The following is a description of a gene set: species: Mus musculus Genes predicted to be targets of miRBase v22 microRNA mmu_miR_6985_3p in miRDB v6.0 with MirTarget v4 prediction scores > 80 (high confidence targets). Mouse Gene Set: MIR_6985_3P from publication Chen Y, Wang X (PMID 31504780), and this is the list of marker genes: Dcaf12, Vgf, Tead1, Rreb1 (NCBI Gene Id 68750), Bcor, Insyn2a, Rpn2, Dio1, Arih2, Cd99l2, Nhlh2, Wnk2, Vdac3, Cyp2c50, Sv2b (synaptic vesicle glycoprotein 2b), C2cd2, Apaf1, Hsdl1, Strbp, Ror1, Tmem170b, Sox8, F8, Trim6, Spesp1, Grm5, Myh9, Tsc22d2, Ptbp2, Fndc3a, Bltp1, Gata2, Slc5a1, Tmem178b, Cnr1, Spata13, Rpgrip1l, Gns, Chst2, Amotl2, Atad2b, Mme, Slitrk6, Gcc2, Nup58, Insm2, Tmem161a, Zhx1, Mknk2, Patz1, Slc35f1, Gpd2, Homer1, Dyrk1a, Eya1, Zbtb33, Usp46, Gata3, Pdzk1ip1, Bcl10, Dzip1l, Dtx4, Plppr4, Map1b, Ufsp2 (NCBI Gene Id 66429), Zfp36, Nipal4, Cpeb3, Cdh11, Gramd1c, Fbxo46, Acer2, Slc39a6, Dnajc5b, Apc, Sox11, Stx8 (syntaxin 8), Gse1, Braf, Il6ra, Mrps14, Cds2, St6galnac3, Btg1, Appbp2, Chn2, Midn, Ino80d, Atp5mc3, Serf2, Edil3, Fbxw7, Lctl, Slc7a11, Mmd, Chd7, Kpnb1, C2cd5, Raph1 (NCBI Gene Id 77300), Tia1, Hoga1, Abhd17c, Adamts6, Nlk, Cdk5r1, Pdha1, Ppm1k, Sall2, Edrf1, Rps6kb1, Dmrt3, Gbp3, Dusp18, Syn2, Id4, Chic1, Pclo, Ncald, Frmpd3, Rap2b, Nedd1, Klhdc3, Limk2, Ing5, Runx1, Usp9x, Csnk1d, Hipk3, Ttyh3, Adrb2, Frmd6 (FERM domain containing 6), Pds5b, Dmxl2, Arl6ip1, Trappc8, Sv2c, Zfp217, Prl2a1, Unc5d, Plcl2, Odf2, Trim66, Zmym4, Galnt1, Zbtb34, Nr5a2, Fbxo34, Marchf6, AU040320, Ube2n, Ncapg, Cdyl, Rbm12, Cnot1, Pparg, Zbtb18, Ppif, Epha7, Slc25a53, Pex19, Clec4e, Rab14, Sema3b, Tox, Btg2, Yipf5, Ammecr1l, Shroom2, Camk2a, Asph, Tnrc6b, Pdia5 (NCBI Gene Id 72599), Stx5a, Tab3, Bltp3a, Nras, Glra2, Samd4, Dpf1, Sv2a, Kras, Gimap6, Fzd4, Arfgef1, Eri3, Kif3a, Ap1g1, Npas3, Colgalt2, Cav1, Necap1, Dpyd, Zbtb10, Tma7, Dnaja1, Sult1a1, Eef1b2, AI593442, Adamtsl3, Klf17 (NCBI Gene Id 98794), B3gnt7, Xpo1, Kctd8, Pianp, Rassf3, Acly, Msn, Mideas, Hdx, Plekhj1, Tmem59, Prr14l, Hmgn1, Sema6a, Zfp106, Pkn2, Zfp850, Clk2, Septin11, Pip5kl1, Ampd3, Chmp3, Ctr9, Ccnyl1, Naa15, Syt14, Fam98a, Txn2, Atp13a3, Ap1s3, Larp4, Usp45, Slitrk1 (NCBI Gene Id 76965), Septin6, Tcf7l2, L2hgdh, Pvalb, Celf1, Ugcg, Osbpl11, Rnf111, Afap1, Arl4c, Cds1, Stradb, Kmt5b, Ikzf1, Fam168b, Coa5, Dcun1d4, En2, Tardbp, Dusp2, Mlxip (MLX interacting protein), Map3k2, Kif21b, Akirin1, Rbfox1, Calm3, Miga2, Slc25a25, Vav2, Nqo2, Creb1, Mtmr4, Maip1, Zeb2, Dipk1a, Srp19, Gzf1, Slc35f4, Lonrf1, Rgs8, Gxylt1, Trim37, Sema4c, Lpin1, Mmp16, Tfcp2l1 (NCBI Gene Id 98219), Smad5, Rnf7, Chka, Cyp2c54, Ippk, Brpf3, Hephl1, Klf8, Kbtbd8, Sp6, Dnajc13, Slc35a3, Cenpw, Usp25, Tmem199, Cald1, Lin7a, Plk2, Itsn2, Kat2b, Csnk1g1